Given this list of marker genes AOAH, VIPR2, CBR1, GRK5, FMO1, BMP7, CXCL11, ARHGAP35, PDGFRA, DENND2B, ROR2, CDH11, DHX8, DELE1, LTF, ORC1, RGS4 (NCBI Gene Id 5999), HNF1A, CRYBA4, GPKOW, EXOSC9, MC1R, ENG, ERF, MYLK, CASP9, SLC6A11, FZD2, EYA2 (EYA transcriptional coactivator and phosphatase 2), CP, CDK10, SAA1, POMZP3, BDKRB2, MAPK1, ZFR, CNN1, ETS1, TRIO, S100A1, HOXB5, HBEGF, EGR3, AGXT, P2RX4, SNX19, DEFA1, RAD54L, DNTT, VDR, TNNI2, TARBP2, PWP2, DHCR24, MYO5A, DRP2, FXYD3, XPA, KLK6, TBXAS1, HLX, FOLR2, FAP (NCBI Gene Id 2191), SMAD3, ZNF212, DGCR2, SKIC2, MAT1A, MYL9, CHRNA2, SLC1A4, WASF3, TROAP (NCBI Gene Id 10024), IL15RA, HTR6, PPP5C, NRG1, PRKCQ, MAPKAPK3, COL9A3, CRADD, TOB1, CSF3R, PPP1R1A, ACR, GDF15, THBS4, here is a description of the gene set: Human Gene Set: MODULE_138 Genes in the cancer module 138. studied in species Homo sapiens